Given this list of marker genes FGF7, GAB2, ERBB4, TSC2, SRC, CD19, FGF9, ESR1 (estrogen receptor 1), PTEN, BDNF, NR4A1, PIK3CA, FGF20, ERBB3, CASP9, MDM2, IRS1, FGFR3, GRB2, RAC1, FGF10, PTPN11, EGFR, FGF17, FGFR4, NTRK2, GAB1, NTF3, TGFA, BAD, RHOG, AKT2, MLST8, KL, RPS6KB2, PIK3CG, PIK3R6, NRG2, EPGN, FGF1, AKT1 (AKT serine/threonine kinase 1), AKT1S1, ESR2, PDGFRA, FOXO6, VAV1, FLT3, FGF5, FOXO1, PIK3R5, FOXO4, BTC, FGF4, FGF3, FGF6, HBEGF, ICOS, RICTOR, FGFR1, AKT3, MAPKAP1, TRAT1, CD86, FOXO3, GSK3B, FGF18, ERBB2, STRN, EGF, RAC2, PDGFA, PDGFRB, HGF, PIK3R1, LCK, IRS2, NTRK3, CHUK, FGFR2 (fibroblast growth factor receptor 2), KITLG, NRG4, KLB, NRG1, PIK3R2, PDGFB, PIK3AP1, MET, AREG, EREG (NCBI Gene Id 2069), FRS2, CDKN1B, FLT3LG, FGF2, PIK3CD, NRG3, PIK3R3, FGF8, FYN, PDPK1, CREB1, CDKN1A, MTOR, FGF16, GSK3A, FGF19, KIT, PRR5, NTF4 (NCBI Gene Id 4909), FGF22, CD80, PIK3CB, FGF23, CD28, here is a description of the gene set: Human Gene Set: REACTOME_PI3K_AKT_SIGNALING_IN_CANCER PI3K/AKT Signaling in Cancer studied in species Homo sapiens